Given this list of marker genes Mgst2, Cyp4f40, Tlr4, Prg3, Lta4h, Alox12, Cyp4f18, Ptgr1, Ggt5, Mgst3, Cyp4f13, Syk, Abcc1, Cyp4a31, Fcer1a, Pla2g4a, Alox5, Ltc4s, Ncf1, Cyp4f15, Cyp4a32, Alox5ap, Dpep1, Cyp4a10 (cytochrome P450, family 4, subfamily a, polypeptide 10), Pla2g5, Tlr2, Cyp4f14, Abcc10, Dpep2, here is a description of the gene set: species: Mus musculus The chemical reactions and pathways involving leukotriene, a pharmacologically active substance derived from a polyunsaturated fatty acid, such as arachidonic acid. Mouse Gene Set: GOBP_LEUKOTRIENE_METABOLIC_PROCESS